The following is a description of a gene set: Human Gene Set: GSE42724_B1_BCELL_VS_PLASMABLAST_DN studied in species Homo sapiens Genes down-regulated in B lymphocytes: B1 versus plasmablasts. The recent discovery of the human B1 cells, identified by the expression of CD20, CD27 and CD43 in absence of expression of CD70 and CD69 has been subject of debate. Some studies have raised the possibility that these cells are B cells differentiating towards the plasmablast and plasma cell stage rather than being the human counterpart of murine B1 cells. No further in depth studies have been performed. Therefore, a functional comparison was made between, the proposed B1 cells and plasmablasts. We observed that for several functional characteristics (distribution of isotypes of spontaneously producted antibodies, production of antigen-specific antibodies after vaccination with both T-cell dependent as well as T-cell independent antigen, the proposed B1 cells behaved similar to plasmablasts. In addition, we were able to differentiate the proposed B1 cells in vitro, indicating that they are not from a distinct lineage as the murine B1 cells. Gene expression analysis revealed that these cells cluster between memory B cells and plasmablasts, contradicting them being the genuine human counterpart of murine B1 cells, rather revealing a preplasmablast phenotype. from publication Covens K, Verbinnen B, Geukens N, Meyts I, Schuit F, Van Lommel L, Jacquemin M, Bossuyt X (PMID 23613519), and this is the list of marker genes: TCTN3, LDHB, SCUBE1, ZNF124, SOX18, ZBTB11, TUBGCP5, OTULIN, RFX1, TRIM24, NARS2, C6orf62, MTRR, PDPK1 (NCBI Gene Id 5170), MFSD5, SERPINB6, TSPAN14, RGS19, ENSA, ADAMTS10, DOCK2, IFNGR1, GLG1, KRT25, CBFA2T2, XRCC1, HIGD2A, MEF2D, TMEM106C, ORC5 (origin recognition complex subunit 5), EIF2AK3, MIGA1, BIVM, NOSTRIN, DENND11, TMEM14A, NEURL4, NIT1, LSP1, FXR2, ARMH3, EIF3A, EIF4A1, UBQLN2, ITM2C, FUCA1, ATP5MC2, SLC6A16, FBXW4, NR2C1, OSBPL8, CHMP7, UBR7, SMC3, RWDD2A, EMC2, ZBTB33, KANSL2, GOLPH3L, COPS7A, NCDN, SNX32, RBFA, MEX3D, ECHDC1, FBXL17 (F-box and leucine rich repeat protein 17), HYCC2, NFAM1, ZNF32, DEF8, RAP1A, OAZ1 (ornithine decarboxylase antizyme 1), C8orf82, INPPL1, TCEAL1, DDX19A, MRPL24, NCBP2AS2, ZFP90, TSPAN4, ALKBH7, PTS, NUMBL, FBXO3, TMEM104, ATP6V1C1, PHF7, ZNF266, SERAC1, SMPD1 (NCBI Gene Id 6609), ZCCHC24, USE1, LDB1, S1PR1, WASHC2A, TDRD3, APPL2, BBS7, DHX32, RAC1, RMND1, PAIP2, CUL7, PEPD, TMLHE, HSCB, NLRC3, PNKP, PCGF1, LONRF1, CAMK2G, UTP15, RCOR3, FAM91A1, LRP6, CBY1, CRELD1, NDUFA13, ZNF688, VASH2, DHRS3 (dehydrogenase/reductase 3), SCFD2, TECPR1, MAT2A, AMDHD2, ABHD14A, ZFYVE1, TRIAP1, SDHAF2, PLA2G2E, SLF2, MAEA, ERI3, GPR180, CCDC141, NTPCR, PRKRA, NIPAL3 (NCBI Gene Id 57185), HTATIP2, ITGB3, KCTD2, C16orf54, PCDHB12, SLC39A9, RANBP10, STT3B, ARHGDIB, GPSM3, NBR1, DIPK2A, SYS1, DPP7, CELA1, BLOC1S2, ETFDH, CIAO1, ZFAND1, NEK4, EIF2B4, MINDY1, CRYZL1, PRPF6, ARHGAP30 (NCBI Gene Id 257106), DSTYK, CLDN18, PLSCR4, FAM120B, LCMT2, CHCHD2, ADIPOR2, NUDT16, PLD2, FLI1, CEP170B, TAF8 (TATA-box binding protein associated factor 8), EMSY, RNF5, ZBTB44, MAML1, KANSL1, PKD2, STK11, TMUB2, IMPACT, TMT1A, ZFP36L2, WDR18, APRT, AKAP11, ATE1, GPR160, ARRDC2, PHF14, PDHA1, FAM118A, ZNF280C, HS6ST1, COASY, GATAD2B, CNRIP1